The following is a description of a gene set: Mouse Gene Set: GOCC_RNAI_EFFECTOR_COMPLEX species: Mus musculus Any protein complex that mediates the effects of small interfering RNAs on gene expression. Most known examples contain one or more members of the Argonaute family of proteins., and this is the list of marker genes: Mir338, Mirlet7i, Mir23a, Mir467a-5 (NCBI Gene Id 100526487), Mir324, Mir30c-2, Mirlet7b, Mir467a-10, Mir467a-9, Mir219a-2, Mir361, Mir124a-1, Mir1a-2, Mir222, Limd1, Mir451a, Mir466d, Mirlet7f-2, Mirlet7f-1, Mirlet7d, Mir669c, Mir19b-1, Dcp2, Mir16-2, Mir486, Mir1839, Mir1a-1, Mir106a, Mir101a, Mir374c, Mir181c, Mir652, Mir21a, Mir145a, Mir467a-6, Ago2, Mir3968, Mirlet7a-2, Ago3, Mirlet7c-1, Mir467a-4, Mir30c-1, Eif2c5l, Tnrc6a, Mirlet7c-2, Mir326, Xpo5, Mir322, Mir500, Mir219a-1, Mir342, Mir19b-2, Mir124a-3, Mir467a-3, Mir140, Mir139, Mir466m, Mir194-1, Snd1, Dicer1, Mir451b, Mir5128, Mir744, Mir5100, Mir150, Mirlet7a-1, Mir455, Mir17, Ago1, Mir20b, Mir144, Mir467e, Mir34c, Mir467a-7, Mir3473b, Mir1981, Mir669f, Mir331, Mir122, Mir298, Mir467a-1, Mir101b, Mir30a, Mirlet7g, Mir362, Mir7-1 (NCBI Gene Id 723902), Mir708, Mir374b, Mir5106, Mir27a, Mir106b, Mir194-2, Mir29a, Mir505, Mir16-1, Mir466h, Ddx6, Mir26b, Mir467a-2, Mir345, Mir532, Mir26a-1, Mir467a-8, Eif4e (eukaryotic translation initiation factor 4E), Mir20a, Mir669o, Mir195a, Mir5099, Mir15b, Mir3068, Prkra, Mir124a-2, Mir221, Mir28a, Mir466g, Mir328, Mir350, Mir320, Ago4, Dhx9, Tarbp2, Mir26a-2 (NCBI Gene Id 723962)